Given this list of marker genes PNPLA7, APOC1, PLA2G7, PLB1, SCARB1, PLA2G10, PLA2G4A, PLA2G15, ENPP2, PNLIPRP2, PNPLA8 (NCBI Gene Id 50640), LDLR, PLA2G6, PLA2G5, LIPC, GDPD3, here is a description of the gene set: Human Gene Set: GOBP_PHOSPHATIDYLCHOLINE_CATABOLIC_PROCESS studied in species Homo sapiens The chemical reactions and pathways resulting in the breakdown of phosphatidylcholines, any of a class of glycerophospholipids in which the phosphatidyl group is esterified to the hydroxyl group of choline.